Given this list of marker genes BTBD19, SERPINA9, SELE, ITM2C, STUB1, HOXB1, SH3BP2, FGF17, OTOR, MTSS2 (MTSS I-BAR domain containing 2), RADIL, NKX2-4, TMEM158, MBOAT4, LRRC46, WNT3A, MTIF3, RRP7A, IFI35, PML, YJU2, PADI1, PDE3A, ZBTB4, BPIFA1, BLVRB, GAP43, TRH, PBXIP1, SSPN, TREH, GCHFR, NR2F1, SLFN13, MDFI, SYT13, FLRT3, DROSHA, BUD31, MIR1915HG, MS4A15, ACOT13, ARHGAP39 (Rho GTPase activating protein 39), GPC6, KRT17, PRDM16-DT, TRIM2, OAS2, MYF6, PPP1R3F, ADGRG2, DMTF1, CHST7, MMP23B, SLC22A18, LRRC8E, ARHGAP30 (Rho GTPase activating protein 30), ASPHD2, NUDT17, QSOX1, CRYGD, TSKS, ITGA2B, NGFR, TMEM86A, CRLF1, TMEM116, APOA4, POMT2, TMEM51, MSANTD3, EPB41L4A, CTSE, SLC1A7, MTRFR (mitochondrial translation release factor in rescue), CKLF, LMCD1, CCND2, NIBAN3, ABCA13, ASB17, NMT1 (NCBI Gene Id 4836), TLE5, RIGI, UBXN4, CYC1, TBX22, MYO1A, GPIHBP1, ARL4A, TTC7A, NELL2, ESRRG, FBN2, TNFRSF11A, MS4A10, CHPF2, TONSL, OR51B4, TRIL, PIP5KL1, HAPLN1, NDUFB8, ADAT3, CPZ, KDR, MTHFSD, NAALADL1, CDH4, RRH, RGL2, PRNP, SOX17, SLCO2B1, KLF1, IFFO2, TSPAN15, BRD8, SDK2, FGFR3, PIWIL2, TLX2, SFXN5, IGSF23, CYSRT1, ACTL6B, EFNB1, FETUB, SMOC1, MVK, RSAD2, PAX4, OAS3, SNRNP48, NSMF, TSPO, IRGC, IFIT1B, FUT7, PRSS50, SERPINB11, RRP9, TMPRSS11D, CCDC169, LRFN3, C1orf174, ILDR2, SERPINC1, PRCD, WEE2, MAGIX, ACRBP, PIGV, LZTR1, DTX1, CYB5R2, MGLL, ARPIN, OPRD1, SPATA25, REEP5, USP18, INSM2 (INSM transcriptional repressor 2), CCDC12, HAPLN3, ZCCHC2, ADRM1, MEDAG, SCGB1A1, CR2 (complement C3d receptor 2), SNTG1, MSL2, FLII, MBL2, TTLL13, ODAD1, NOTCH4, MX2, PODXL2, STARD3, COMMD9, NUDT1, NTSR2, LRRC17, CLEC11A, SLC22A3, LRTM2, TMEM104, SDC2, SLFN5, ZNHIT1, PDCD1, MANF, FBRSL1, C16orf95, COL4A4, LBX1, KRT86, C12orf57, here is a description of the gene set: Bcl6 germline deletion causes a prominent inflammatory disease, owing to over-expression of Th2 cytokines, and affects the properties of B cells prior to immunization. Therefore we established the B cell-specific Bcl6 deletion mice and analyze the gene expression of naive B cells under physiological conditions. from publication Kaji T, Ishige A, Hikida M, Taka J, Hijikata A, Kubo M, Nagashima T, Takahashi Y, Kurosaki T, Okada M, Ohara O, Rajewsky K, Takemori T (PMID 23027924) Human Gene Set: GSE28737_WT_VS_BCL6_KO_MARGINAL_ZONE_BCELL_UP studied in species Homo sapiens Genes up-regulated in marginal zone B lymphocytes: wildtype versus BCL6 knockout.